Given this list of marker genes BCL3, ARRB2, NFKBIA, IKBKB, SSPOP, RELA, REL, CSNK2A2, SYK, CSNK2A1, CSNK2B, SRC, PIK3CA, MAPK14, PIK3R1, NFKB1, LCK, here is a description of the gene set: studied in species Homo sapiens Human Gene Set: PID_NFKAPPAB_ATYPICAL_PATHWAY from publication Schaefer CF, Anthony K, Krupa S, Buchoff J, Day M, Hannay T, Buetow KH (PMID 18832364) Atypical NF-kappaB pathway